Given this list of marker genes Iqgap3, Csf1, Syde1, Fbp1, Dok2, Rit1, Ntrk1, Dgkz, Sdcbp, Lztr1, Ralgps1, Rapgef6, Notch1, Syngap1, Spry2, Cdkn1a, Nrg1, Icmt, Mapkapk5, Rgl3, Rala, Rasal1, Shtn1, Rasal3, Plk2, Nup62, Cdk2, Src, Cnksr1, Rasa3, Rasgef1c, Dgki, Erbb3, Tgfb2, Eras, Rasa4, Rfxank, Rasgrf2, Ksr1, Ccna2, Foxm1, Ppp2cb, Nf1, Itpkb, Hras (NCBI Gene Id 15461), Rit2, Rassf1, Nras, Rasgrp4, Rapgef2, Ralgds, Sh2b2, Rapgef3, Ephb2, Plaat1 (NCBI Gene Id 76363), Rabl3, Rsu1, Rasgrp1, Rapgefl1, Usp50, Rasa2, Map2k1, Trim67 (NCBI Gene Id 330863), Fgf10, Mapkap1, Rasgrf1 (RAS protein-specific guanine nucleotide-releasing factor 1), Ntn1, Timp2, Dok3, Igf1, Sos1, Arl6, Tnk1, Plce1, Brap, Syde2, Rapgef1, Trp53, Dab2ip, Lat, Stk19, Rasgrp2 (NCBI Gene Id 386467), Shoc2, Ngf (NCBI Gene Id 18049), Rgl1, Rasgef1b, Spry1, Rasgrp3, Kitl, Dhcr24, Mras, Kras, Rasgef1a, Rabgef1, Mfn2, Ulk1, Grb2, Ksr2, Rb1, Sos2, Notch2, Epo (erythropoietin), Spry4, Stambp, Picalm (NCBI Gene Id 233489), Rapgef4, Usp8, Ralgps2, Ralb, Dok1, Flcn, Erbb2, Rapgef5, Rras2, Mmd2, here is a description of the gene set: Mouse Gene Set: GOBP_RAS_PROTEIN_SIGNAL_TRANSDUCTION species: Mus musculus An intracellular signaling cassette in which a small monomeric GTPase of the Ras subfamily relays a signal.